The following is a description of a gene set: species: Homo sapiens Translesion Synthesis by POLH Human Gene Set: REACTOME_TRANSLESION_SYNTHESIS_BY_POLH, and this is the list of marker genes: RFC3, RFC4, PCNA, NPLOC4, RFC5, RPA3, RPS27A (ribosomal protein S27a), UBB, UFD1, RPA2, RPA1, UBC, SPRTN, POLH (DNA polymerase eta), VCP, RCHY1, UBA52, RFC1, RFC2